The following is a description of a gene set: Genes predicted to be targets of miRBase v22 microRNA mmu_miR_340_3p in miRDB v6.0 with MirTarget v4 prediction scores > 80 (high confidence targets). from publication Chen Y, Wang X (PMID 31504780) studied in species Mus musculus Mouse Gene Set: MIR_340_3P, and this is the list of marker genes: Il11ra1, Rpe65, Acbd5, Vav3, Il11ra3, Dusp8, Mapk12, Med27, Adamts9, Serpinb10, Tmem145